The following is a description of a gene set: species: Homo sapiens EEG with parietal epileptiform discharges Focal epileptiform EEG discharges recorded in the parietal region. Human Gene Set: HP_EEG_WITH_PARIETAL_EPILEPTIFORM_DISCHARGES, and this is the list of marker genes: TFE3, TBC1D24, TRIM8, ADGRG1 (NCBI Gene Id 9624), PI4KA, SRPX2